The following is a description of a gene set: The controlled breakdown of any cell membrane in the context of a normal process such as autophagy. Mouse Gene Set: GOBP_MEMBRANE_DISASSEMBLY studied in species Mus musculus, and this is the list of marker genes: Ndel1, Atr, Dctn1, Akap8l, Cdk1, Plk1, Plaat3, Pafah1b1